Given this list of marker genes MEF2D, ZNF595, EPC2, PCOLCE2, JMY, FAM135A, FBXW7, SOSTDC1, APPL1, SLC9A7, PLEKHA1, SYNJ1, TBL1XR1, SLC32A1, GOLGA3, TBC1D12, PSMD14, MPP1, GOLGA8A, MIER1, KLF2, COX20, RANBP9, NCAPH2, GATA6, SOX11 (SRY-box transcription factor 11), PPP1R12A, ZNF24, BCAT2, FNIP1, PTPRO, SETD5, MTF1, CNIH1, BTG2, TOB2, NPC1, MCL1, GLRA1, DYRK2, REXO1, ZNF385D, TRIM36, TEAD1, BAZ2B, C8orf44-SGK3, GLCE, ARRDC3, XPNPEP3, LONRF3, LATS2, TEX2, FZD10, UCHL5, LYST, ADAM19, CBFA2T3, ITPR1, ZFAND1, DMXL1, RHPN2, CDKL5 (NCBI Gene Id 6792), GLYR1, USP36, KMT5B, PCGF3, NEFH, MARCHF6, PPP1R12C, EFR3A, HIPK1, PRKAR2B, CLDN11, ADAMTSL1 (ADAMTS like 1), PNISR, DENND1B, CLCN5, KLHL29, RAB14, GPC6, ELOVL4, APBB2, AGO3, INSIG1, NUFIP2, GOLGA1, GFPT2, ITGA5, GRAMD2B, DPP10, EDEM1, SNN, MYO5A, ADRB1 (NCBI Gene Id 153), FNBP4, MFF, ANP32E, RAB23, CHCHD10, PTGER4, UBXN4, MAPK8, SCAF11, TPCN1, PTPRD, EPG5, RAB8B, ELK4, SYN2, SLC25A32, COL1A2, FAM20C, TAGAP, SLC25A16, DUSP10, MMD, CIC, USP28, FXR1, SCUBE3, RBPMS2, CADM2, TCF21, CCNC, G3BP2, IDH1, TMEM267 (NCBI Gene Id 64417), ADCY3, PIK3R3 (phosphoinositide-3-kinase regulatory subunit 3), SNAP91, SLC9A1, ANO8, STRN3, MAN2A1 (mannosidase alpha class 2A member 1), CPNE8 (NCBI Gene Id 144402), TAFA1, CCDC186, KLHL15, XYLT2, LHFPL2, SGPP1, NPNT, ZC2HC1A, ANKRD44, TRIO, PCDH11Y, MYCBP2, NSF, PLEKHB2, ZNF521, SRPRA, SLC4A8, C19orf12, SCN8A, FCHO2, CDK16, ELOA, GATA2, ZNF827, LRCH1, PTAR1, PTEN, MAP2K4, ARRDC4, TET2, MFHAS1, PKDCC, MTMR9, RNF4, RNF180, WWP2 (WW domain containing E3 ubiquitin protein ligase 2), CACNA1I, FHIP1B, KLHL14, KLF8, PGBD2 (NCBI Gene Id 267002), ADAM10, GTF2A1, DDX3X, SPRYD4, HIVEP1 (HIVEP zinc finger 1), ANKIB1, IBTK, ASPN, ARF1, SLC12A5, GID4, AFF3, CDCA7L, EVI5, FMN2, FHL2, ATXN3, MAP1B, LRRC1, FAM24A, BCL2L11, EDEM3, PLXDC2, LIMCH1, BCL11B, MYH9, COG3, PPCS, GPR158, PAX9, CNEP1R1, RIC1, SERTAD3, ARMC1, SLX4, SOX4, GPR137C, BSDC1, RGS3, C11orf24, SLC39A8, SLC38A2, NFYB, UBE2W, TENT4A, CSMD3, FRY, HIPK3, PLEKHG3, GNAQ, GNPDA2, PAPSS2, CUX1, TNPO1, SESN3, CTTNBP2, MYO1B, TOB1, DNAAF9, DUS2, ZEB2, ZFC3H1, IQGAP2, HCN2, FNIP2, FOXN2, NSMAF, TTC9, PDZD2, ZNF721, TEF, PHLPP2, HS3ST5, KAT2B (NCBI Gene Id 8850), DENND4B, ITGA6, AADACL3, ESRP1, NF2, NEFM, NSMF, MAST4, NOX4, ADGRF2P, ARID1B, ATG14, PPP1R37, MIA3, DAAM1, ANKRD28, PCDH11X, USP45, KLF4, RPS6KA4, C5orf24 (NCBI Gene Id 134553), STYX, PITPNM2, GIT2, PDZD8, TMEM255A, ZFYVE21, BLTP1, SLC7A11, SH3PXD2A, OTUD3, ROBO2, HYCC2, C6orf62, DNAJB12, RSBN1, SNAPC1, PITPNA, TBC1D8, JOSD1, BCL11A, COL19A1, RORA, PTPRJ, MMP10, SLC24A3, CXCL5, TMEM229A, ATRX, GPR180, FBN1, BSN, ERGIC2, P3H3, BAHCC1, ATP6V1B2 (ATPase H+ transporting V1 subunit B2), CPEB4, SEMA3A, UBASH3B, DCAF6 (DDB1 and CUL4 associated factor 6), MACIR, GRHL1, UGP2, MOAP1, DDX3Y, RNF44, GOLGA4, HNF1B, HAND2 (NCBI Gene Id 9464), DUSP5, SH3D19, TGIF1, FHIP2A, CBLN4, CPEB2, TULP4, SGK3, CD2AP, ADAMTSL3, RNF38, PCYT1B, NKX2-3, ACTC1, GOLGA7, CCNJL, NR4A3, TWF1 (NCBI Gene Id 82712), ITPRID2, MARCHF4, PIK3CB, KLHDC10, PER2, RAD21, TECPR2, DOCK9, SOCS6, PDE10A, SNX13, RBM47, AIDA, COL27A1, BMPR2, RBM27, REST, LUZP1, CALN1, PAXBP1, DNAJB9 (DnaJ heat shock protein family (Hsp40) member B9), ZFHX4, MSR1, HERPUD2, MAP3K20 (NCBI Gene Id 51784), WASL, CPEB3, RPL15, PRRC2B, FKBP1A, ZDHHC5 (zinc finger DHHC-type palmitoyltransferase 5), ATXN1, LIN54, ACOX1, PHTF2, PEAK1, CELF2, ITGA8, PIKFYVE, RGS17, RNF141, SLC25A36, PCDH7, ARHGEF17, NEFL (neurofilament light chain), ST6GAL2, RFX1, NKX2-4, MED19, KBTBD8, SPTBN4, SLC17A6, TPPP, MBOAT2, PIAS4, SELENOT, EOMES, MORC3, B3GALT2, VPS4B, DSC2, RIMS2, ALKAL2, MINAR1 (membrane integral NOTCH2 associated receptor 1), ARHGAP24, ABHD13, PTPRK, TACC2, OSBPL5, MAGEC2, RAB3C, RGL1, TMF1, NCKAP5, UBE2Z, LMBR1L, PAX3, ITGAV, SSBP2, OTUD4, IL36B, PCMTD1, YIPF4, CD69, CASD1, PALLD, C21orf91, ZNF287, SLC10A7, here is a description of the gene set: from publication Chen Y, Wang X (PMID 31504780) Genes predicted to be targets of miRBase v22 microRNA hsa-miR-367-3p in miRDB v6.0 with MirTarget v4 prediction scores > 80 (high confidence targets). Human Gene Set: MIR367_3P studied in species Homo sapiens